Given this list of marker genes GSK3A, CALR, CDK1, PPARA, PRKG1, TSC1, CTDP1, MTOR, SLC8A1, PRICKLE1, MIR23A, SMAD4, PDLIM5 (PDZ and LIM domain 5), ACTN2, ADPRHL1, IFT20, SLC9A1, ACTC1, MYOCD, RGS4, PLEC, ACVR1, PDGFRA, MIR19B1, MIR208A, SOX6, FHOD3, ATG5, OBSL1, COL14A1, SGCB, ITGB1, LMNA, MYH10, MIR590, FZD7, MIR499A, FRS2, LRRC10, BMPR1A, LARGE1, DLL1 (NCBI Gene Id 28514), YY1, BVES, GREM1, SIK1, NRAP, AKAP13, MEF2A, NKX2-6, MEIS1, ADRA1A, GREB1L, NKX2-5, BMP2, MIR1-1, CTCF, CCNB1, CACYBP, TCAP, ASB2, GATA6, KCNJ8, MIR24-1, MYO18B, HEY2, ARRB2, MIR204, IGF1, TBX5, IRX3, NRG1, NAGLU, ZMPSTE24, RXRB, ALPK2, TBX18, SORBS2, CXADR, FOXP1, AKAP6, ISL1, RGS2, MEF2C, C10orf71, MYH6, RARA, MYH11, TGFB1, PITX2, MIR199A1, NEBL, ACADM, MIR195, PI16 (peptidase inhibitor 16), SIRT6, MIR19A, BMP10, NPPA, VEGFA, NOX4, SHOX2 (NCBI Gene Id 6474), MIR222, NEB, WNT3A, WT1, ALPK3, PROX1, EFNB2, PAK1, MAML1, CBY1, SRF, MIR200B, MYL2, EDN1, GATA4, TOMM70, PARP2, BMP4, G6PD, SGCD, HDAC3 (histone deacetylase 3), PDGFRB, CSRP3, HNRNPU (NCBI Gene Id 3192), KDM6B, CAV3, DKK1, RARB, MESP1, TTN, TBX3, MIR199B, FHL2, KAT2A, MYLK3, here is a description of the gene set: The process in which a cardiac muscle precursor cell acquires specialized features of a cardiac muscle cell. Cardiac muscle cells are striated muscle cells that are responsible for heart contraction. species: Homo sapiens Human Gene Set: GOBP_CARDIAC_MUSCLE_CELL_DIFFERENTIATION